The following is a description of a gene set: This event has been computationally inferred from an event that has been demonstrated in another species.<p>The inference is based on the homology mapping from PANTHER. Briefly, reactions for which all involved PhysicalEntities (in input, output and catalyst) have a mapped orthologue/paralogue (for complexes at least 75% of components must have a mapping) are inferred to the other species. part of: Eukaryotic Translation Initiation electronically inferred by orthology from the curated human pathway studied in species Mus musculus Reactome Pathway: L13a-mediated translational silencing of Ceruloplasmin expression, and this is the list of marker genes: Eif1ax, Ubb, Rps8, Rpl3l, Rps4x, Rps11, Rpl36al, Rpl18a, Rpl18, Rps9, Rps12, Rps24, Rpl24, Rpl11, Rpl38, Rps18, Rpl19 (ribosomal protein L19), Fau, Rps6, Eif3g, Rpl7, Eif3d, Rpl39, Rpl37rt, Rpl15, Rpl26, Rps23, Rps2, Eif4a2, Eif3f, Eif4a1, Rps10, Rpl39l, Rpl14, Rpl27a, Pabpc1, Rpl37a, Eif2s3x, Rpl23a, Rpl36a (NCBI Gene Id 19982), Rps7, Rps13, Rps25, Rps27l, Rpl13, Eif3k, Rps17, Rps20, Rps26, Eif3e, Eif3i, Rpl27, Rps5, Rpl6, Rps28, Rpl29, Rpl4, Eif3j2, Rps15, Rpl37, Rps3a1, Eif3b, Rpl3, Rplp2, Rps19, Rpl12, Rpl9